The following is a description of a gene set: studied in species Homo sapiens Pathogenesis of SARS-CoV-2 mediated by nsp9-nsp10 complex Human Gene Set: WP_PATHOGENESIS_OF_SARSCOV2_MEDIATED_BY_NSP9NSP10_COMPLEX, and this is the list of marker genes: CRP, ZAP70, NKRF, CD8B, PRG3, LCK, IGLL1, CXCL8, CD2, HLA-DRA, CD4 (CD4 molecule, NCBI Gene Id 920), FYN, CD8A, CD3E, MMP25, LBP, IL6, HLA-DRB1, HLA-DRB5, CD247, CD3G